The following is a description of a gene set: CD4 T follicular helper (Tfh) cells provide the required signals to B cells for germinal center reactions that are necessary for longlived antibody responses. However, it remains unclear whether there are CD4+ memory T cells committed to the Tfh lineage after antigen clearance. Using adoptive transfer of antigen-specific memory CD4+ subpopulations (based on CXCR5 and Ly6c expression)in the LCMV infection model, we found that there are distinct memory CD4+ T cell populations with commitment to the Tfh and Th1 lineages. Our conclusions are based on gene expression profiles, epigenetic studies and phenotypic and functional analysis. The gene expression profiles of virus-specific CD4 T cell subets at effector and memory stages is presented here. species: Homo sapiens from publication Hale JS, Youngblood B, Latner DR, Mohammed AU, Ye L, Akondy RS, Wu T, Iyer SS, Ahmed R (PMID 23583644) Genes down-regulated in Th1 CD4 SMARTA T cells: effector during acute infection of LCMV versus memory. Human Gene Set: GSE43863_DAY6_EFF_VS_DAY150_MEM_TH1_CD4_TCELL_DN, and this is the list of marker genes: ATP5MC2, GBP2, CBLB, PECAM1, DDX11, RHBDL3, CD200, YTHDF3, TLCD1, IL12B, DUSP16, PPAT, BTBD3, BCL2L1, PFDN2, RRAS2, PUM2, FCER2, TBL1X, FFAR4, CRHR2, FCRL1, ID1, EBI3, CD44, TBX21, PLXND1, KIAA0040, HYCC1, BASP1, RBM26, MYBL2 (MYB proto-oncogene like 2), ARID1A, RAB34, DENND5A, CFLAR, ZNF281, PEX14, LSG1 (NCBI Gene Id 55341), IRGM, SLC7A3, TNFRSF13B, DPP4, EID3, CA13, TAGLN2, B3GALT6, MXI1, SFXN1, IL2RA, ARAP2, IL6, SLC17A7, OSM, GRAMD2B, RIC1, USP22, KCTD14, PLVAP, CACNA1S, CARM1, PUS7, SLAMF1, HCK, C21orf91, BCL3, ANKRD40, MAPKBP1, HNF1B, ZRANB1 (NCBI Gene Id 54764), DUSP10, GIMAP4, CD81, MLLT6 (MLLT6, PHD finger containing), ZFTA, ETV3, MRTFA, RND3, TNFAIP3, UBALD2, ZNF710, LTA, KSR1, PCGF5, IRF9, SH3BP4, WEE1, FUT8, NFKBIZ, GMEB2, FSCN1, AEBP2, PIKFYVE (phosphoinositide kinase, FYVE-type zinc finger containing), EZH2, SOCS3, CCDC88C, LAG3, PELI1, ACTN1, CARD6, OPTN, BATF, NCAM2, PCMTD1, ABCA7, STRIP2, SOX30, FAM89A, CPNE3, HACD3, PFDN4, IL12A, GPR18, CCR7, IL10, SMAGP, FAM107B, SKIL, PRKAA2, NFIL3, IFNLR1, TSPAN2, BEND5, CDCA2, PDE3B, UBOX5, HSD11B1, SMARCE1, HEATR6, BBX, CASC3, HIVEP1, B3GNT2, PXN, ICOSLG, RBMS1, MYEF2, RFX5, LAP3, UBTFL1, BIRC3, PLXNC1, PIM2, CD19, IGFBP4, DNAJC21, CDC27, CRTC2, JUN, PHIP (pleckstrin homology domain interacting protein), N4BP2L1 (NCBI Gene Id 90634), GCOM1, RICTOR, LNPEP, ZMYND8, GBP4, SETDB1, MFHAS1, SELL, SYPL1, YAE1, TMCC3, LY6D, PPM1K, CLCF1, SWAP70, AKNA, TET2, NIBAN3 (NCBI Gene Id 199786), NFKB1 (nuclear factor kappa B subunit 1), TCF3, AGRN, NIBAN1, LIPF, RANBP1, TLR1, NPHP3, BABAM2, CXCL10 (C-X-C motif chemokine ligand 10), UBTD2, ARHGAP30, NCF1, HK2 (NCBI Gene Id 3099), GPER1, MS4A6A, GBP6, UNC93B1, BCL2, SENP5, STK17B, ARID5A, BDH1, ALPL (alkaline phosphatase, biomineralization associated), GADD45B, FGF3, SAPCD1, UGCG, SENP6, DENND3